The following is a description of a gene set: studied in species Homo sapiens Human Gene Set: GOBP_NATURAL_KILLER_CELL_MEDIATED_IMMUNE_RESPONSE_TO_TUMOR_CELL An immune response mediated by a natural killer cell triggered in response to the presence of a tumor cell., and this is the list of marker genes: NKG7, CD160, NECTIN2, IL12B, CRTAM, HAVCR2, CEACAM1, PVR, IL12A, CD226 (CD226 molecule), TGFB1